Given this list of marker genes EGF, ABCA8, MIR301B, NR1H2, PPARG, MIR613, RXRA, NFKB1, MIR33A, MAPK3 (mitogen-activated protein kinase 3), TTC39B, ABCG4, APOE, MIR27B, SREBF2, TREM2, NR1H3, MIR19B1, APOA1, NAXE, SIRT1 (sirtuin 1), MIR302A, LAMTOR1, MIR206, ABCG1, CETP (NCBI Gene Id 1071), MIR26A1, ABCA3, MIR145, CES1, ABCA1, MIR9-1, PTCH1, MIR758, YJEFN3, PLTP, ADIPOQ, MIR144, SHH, MIR33B, GPS2, LRP1, MIR130B (NCBI Gene Id 406920), ABCA2, PLA2G10, MIR27A, CAV1, MIR93, MIR148A, ABCA5, ABCA12, PON1, ZDHHC8, EEPD1, MIR17, ABCA7, MIR128-1, here is a description of the gene set: Human Gene Set: GOBP_REGULATION_OF_CHOLESTEROL_EFFLUX Any process that modulates the frequency, rate or extent of cholesterol efflux. Cholesterol efflux is the directed movement of cholesterol, cholest-5-en-3-beta-ol, out of a cell or organelle. studied in species Homo sapiens